Given this list of marker genes HTR2B, NR1H4, CAPN2, ENPP7, CHP1, RAB38, FABP3, ADGRF5 (NCBI Gene Id 23282), APOC2, SPATA18, HTR2A, PRKCD, TAFAZZIN, ACSL3, HTR2C, XBP1, here is a description of the gene set: Any process that activates or increases the frequency, rate or extent of phospholipid metabolic process. studied in species Homo sapiens Human Gene Set: GOBP_POSITIVE_REGULATION_OF_PHOSPHOLIPID_METABOLIC_PROCESS